The following is a description of a gene set: Mouse Gene Set: GOBP_CELL_CELL_JUNCTION_DISASSEMBLY studied in species Mus musculus The disaggregation of a cell-cell junction into its constituent components., and this is the list of marker genes: Asb17, Mylk3 (myosin light chain kinase 3), Snai2, Abcc8, Tgfbr1, Il1b, Fer, Tgfb3